Given this list of marker genes Cadm1, Farp1, Tenm2, Nlgn1, Dag1, here is a description of the gene set: Cell-cell signaling from postsynapse to presynapse, across the synaptic cleft, mediated by trans-synaptic protein complex. studied in species Mus musculus Mouse Gene Set: GOBP_RETROGRADE_TRANS_SYNAPTIC_SIGNALING_BY_TRANS_SYNAPTIC_PROTEIN_COMPLEX